Given this list of marker genes KIF5B, WNT7A, MAP1A, NETO1, KIF5A, DLG2, RAB27B, KIF5C, HSPB1, DVL1, MAPK8IP3, here is a description of the gene set: Human Gene Set: GOBP_PROTEIN_LOCALIZATION_TO_PRESYNAPSE A process in which a protein is transported to, or maintained in, a location within a presynapse. species: Homo sapiens